Given this list of marker genes IFNE, SPATS1 (spermatogenesis associated serine rich 1), GAN, RNF5, KCTD16, PRDM10, ADGRE2, FKBP1B, GPC5, ANKLE2, C8orf34-AS1, RGS12, FAM120C, NUFIP2, SLC38A5, ZNF605, IQCM, HNRNPA1L2, ROR1, MINAR1, STYK1, TNFSF13B (TNF superfamily member 13b), ETV6, MROH2A, RHPN2, LRRCC1, MDS2, NOXRED1, NBN, HNRNPM (heterogeneous nuclear ribonucleoprotein M), ENSG00000124835, ZRANB2, DUSP4, UBR7, GAPVD1, SAMD4A, HLTF (helicase like transcription factor), WDR26, UBE2E3, AMBP, PRDM2, KMO, VAMP4, MCCC1 (methylcrotonyl-CoA carboxylase subunit 1), TH, NUBP1, GPHN, HYLS1, HMGN3, UTY, ZFPM2, SELENOT, APOH (NCBI Gene Id 350), FSTL5, HIPK4, LMTK3, ZNF804A, YTHDC1, TTN, CALD1, OBSCN-AS1, FNDC1 (fibronectin type III domain containing 1), CEP120, SPPL2A, ZCCHC2, VGLL1 (vestigial like family member 1), ATXN7L1, MICU3, RAB31, BTBD8, NLN, SLCO1B1, MAP3K7CL, GNPDA2, AMIGO2, CACNA2D3, AQP3, LRRC1, LSM5, H2AC8, ADTRP, HIF1A, CNOT9, POLA1, BRMS1L, RBP1, DSC2, MAGEA11, OPRM1, SPTA1, ARID1A, C2CD5, KAT14, FGF13, KLHL32, TM4SF1, SLC12A2, SI, LGALSL, TIGD7, EML1, RNASEH2B, KIDINS220, U2AF2, AJUBA, FCGR1BP, FILIP1L, PRIM2, R3HDML, ZNF268, RABGEF1, BCLAF3, SMARCA2, FAM110B, CLEC5A, ADAM2, BRAF, EARS2 (glutamyl-tRNA synthetase 2, mitochondrial), GPX5, FAR2P1, GREM1, HECTD2, CD300LD-AS1, CTAGE11P, SMG8, PELI2, ANKRD7, CPA6, CKLF, RPL10L, PHAF1, DDX47, GPER1, USP29, SGMS2, CTCF, LNP1, ACTG1P25, RBM20, MERTK, DSE, ZNF84, SLC36A1 (NCBI Gene Id 91974), HBP1, PSRC1, EEA1, KIF20B, NKIRAS1, GPR75, HELLS, CD34, PGM1, CSAD, UBAC2-AS1, NECAP1, FGF18, ERF, NT5C1B, B3GLCT, APBB2, DUSP11, HISLA, C9orf152, ANXA5, MYH2, DIDO1, RIMKLB, ZNF589, CREB5, TMEM217, TAF4B, THBS1, ATF7, TAF8, ALG10, SPICE1, RAB8B, TNMD, GPR137C, HHATL, REG4 (NCBI Gene Id 83998), ELF2, SERPINB9P1, LRRC8C, ALG9, TP73, UBE2D2, ZNF776, OR7E14P, ZNF17 (zinc finger protein 17), here is a description of the gene set: species: Homo sapiens Abstract of publicaton: CD4/CD8 double-positive (DP) thymocytes express the transcriptional repressor Histone Deacetylase 7 (HDAC7), a class IIa HDAC that is exported from the cell nucleus after T cell receptor (TCR) engagement. Through signal-dependent nuclear export, class IIa HDACs such as HDAC7 mediate signal-dependent changes in gene expression that are important to developmental fate decisions in multiple tissues. We report that HDAC7 is exported from the cell nucleus during positive selection in thymocytes, and regulates genes mediating the coupling between TCR engagement and downstream events that determine cell survival. Thymocytes lacking HDAC7 are inefficiently positively selected due to a severely shortened lifespan and exhibit a truncated repertoire of TCR Jalpha segments. The expression of multiple important mediators and modulators of the response to TCR engagement is altered in HDAC7-deficient thymocytes, resulting in increased tonic MAP kinase activity that contributes to the observed loss of viability. Remarkably, the activity of Protein Kinase D, the kinase that mediates nuclear export of HDAC7 in response to TCR signaling, is also increased in HDAC7-deficient thymocytes, suggesting that HDAC7 nuclear export governs a self-sustaining auto-excitatory loop. These experiments add to the understanding of the life/death decision in thymic T cell development, define a novel function for class IIa HDACs, and point to a novel feed-forward mechanism whereby these molecules regulate their own state and mediate stable developmental transitions. Title of manuscript: Nuclear Export of Histone Deacetylase 7 During Thymic Selection Mediates Immune Self-tolerance. abstract of manuscript: Histone Deacetylase 7 (HDAC7) is a TCR signal-dependent regulator of differentiation that is highly expressed in CD4/CD8 double-positive (DP) thymocytes. Here we examine the effect of blocking TCR-dependent nuclear export of HDAC7 during thymic selection, through expression of a signal-resistant mutant of HDAC7 (HDAC7-delta-P) in thymocytes. We find that HDAC7-delta-P Transgenic thymocytes exhibit a profound block in negative thymic selection, but can still undergo positive selection, resulting in the escape of autoreactive T cells into the periphery. Gene expression profiling reveals a comprehensive suppression of the negative selection-associated gene expression program in DP thymocytes, associated with a defect in the activation of MAP kinase pathways by TCR signals. The consequence of this block in vivo is a lethal autoimmune syndrome involving the exocrine pancreas and other abdominal organs. These experiments establish a novel molecular model of autoimmunity and cast new light on the relationship between thymic selection and immune self-tolerance. Goal of Microarray experiment: We did these experiments to determine how alteration of the function of HDAC7, a site-specific and signal-dependent repressor of transcription, changes gene expression in CD4/CD8 DP thymocytes. Genes up-regulated in double positive thymocytes: HDAC7 knockout versus over-expressing HDAC7 fused with VP16. from publication Kasler HG, Young BD, Mottet D, Lim HW, Collins AM, Olson EN, Verdin E (PMID 21398603) Human Gene Set: GSE26488_HDAC7_KO_VS_VP16_TRANSGENIC_HDAC7_KO_DOUBLE_POSITIVE_THYMOCYTE_UP